The following is a description of a gene set: Any process that stops, prevents, or reduces the frequency, rate or extent of establishment or extent of a membrane potential, the electric potential existing across any membrane arising from charges in the membrane itself and from the charges present in the media on either side of the membrane. studied in species Homo sapiens Human Gene Set: GOBP_NEGATIVE_REGULATION_OF_MEMBRANE_POTENTIAL, and this is the list of marker genes: MAPT, PMAIP1, BNIP3, SLC25A27, MIR181B1, MTCH2, ADCY10 (NCBI Gene Id 82259), ARL6IP5, BNIP3L, PRELID1, PIP5KL1, BAX, RNF122 (NCBI Gene Id 79845), LTF